The following is a description of a gene set: Any process that modulates the frequency, rate or extent of endosome organization. Human Gene Set: GOBP_REGULATION_OF_ENDOSOME_ORGANIZATION species: Homo sapiens, and this is the list of marker genes: SYNJ1, PRKN, SCARB2, TOM1, RAB7A